The following is a description of a gene set: species: Homo sapiens Atrophy of the eyeball with blindness and decreased intraocular pressure due to end-stage intraocular disease. Human Gene Set: HP_PHTHISIS_BULBI Phthisis bulbi, and this is the list of marker genes: BRD4 (bromodomain containing 4), NDP, ATOH7, FOXE3 (forkhead box E3), BCOR (NCBI Gene Id 57686), FZD4, MARK3, TAF6 (TATA-box binding protein associated factor 6), NIPBL, SMC3, COL18A1, LRP5, SMC1A, TMEM53, CDH11, HDAC8, RAD21, HMX1